The following is a description of a gene set: studied in species Mus musculus A microtubule in the axoneme of a eukaryotic cilium or flagellum; an axoneme contains nine modified doublet microtubules, which may or may not surround a pair of single microtubules. Mouse Gene Set: GOCC_AXONEMAL_MICROTUBULE, and this is the list of marker genes: Mns1, Nme7, Ribc1, Efhb, Tekt1, Pacrg, Cfap210, Cfap126, Cfap161, Cfap276, Cfap90, Cfap77, Tektip1, Spmip9, Spmip11, Cimip2a, Cfap20, Tekt2, Saxo1, Cfap206, Pierce2, Spaca9, Cfap141, Tekt3, Spmip10, Cfap45, Tekt4 (tektin 4), Ift70a1, Cep162, Cfap107, Cimip2b, Tubb4b, Arfgef2, Tuba1a, Tektl1, Efhc2, Arl6, Spmip6, Dusp21, Pierce1 (piercer of microtubule wall 1), Ift70a2, Cimip2c, Saxo4, Spmip8, Rpgrip1l, Spag8, Cfap52, Spmip5, Efhc1, Ribc2, Ift70b, Cfap53, Enkur, Cfap68, Efcab6, Tekt5 (tektin 5), Cfap144, Saxo2, Cfap95